The following is a description of a gene set: The growing (plus) end of a microtubule. In vitro, microtubules polymerize more quickly at the plus end than at the minus end. In vivo, microtubule growth occurs only at the plus end, and the plus end switches between periods of growth and shortening, a behavior known as dynamic instability. Human Gene Set: GOCC_MICROTUBULE_PLUS_END species: Homo sapiens, and this is the list of marker genes: SPAG5, CLIP4, GAS2L1, PDE4DIP, SLAIN1, DST, MAPRE2, SLAIN2, NUMA1, CLIP1, TBCB, GAS2L2, CDK5RAP2, KNSTRN, CLASP1, MAPRE1, CKAP5, KIF18B, NCKAP5, DCTN1, MAPRE3, CLASP2, KIF2C, CLIP2, CLIP3, NCKAP5L